The following is a description of a gene set: Mouse Gene Set: MIR_3080_3P Genes predicted to be targets of miRBase v22 microRNA mmu_miR_3080_3p in miRDB v6.0 with MirTarget v4 prediction scores > 80 (high confidence targets). studied in species Mus musculus from publication Chen Y, Wang X (PMID 31504780), and this is the list of marker genes: Rpl27a, Frat2, Ccdc81, Inka2, Mybpc1, Otub1, Zfp593, Agap1, Tnfaip8l2, Nod2, Smg6 (SMG6 nonsense mediated mRNA decay factor), Chmp4c, Foxd4, Ark2c, Trub1